The following is a description of a gene set: studied in species Homo sapiens A process in which a protein is transported to, or maintained in, a location within the Golgi apparatus. Human Gene Set: GOBP_PROTEIN_LOCALIZATION_TO_GOLGI_APPARATUS, and this is the list of marker genes: GBF1, LACRT, CSNK1D, RIPOR1, SYS1, RAB6C, RAB41, GOLPH3, GBP5, ARFRP1, VPS13A, ARL5C, PAQR3, GOLPH3L, VPS13D, IFT20, ARL5A, RAB6B, PACS1 (NCBI Gene Id 55690), VPS13C, RAB33B, SORL1, BICD2, TMED10, RAB6A, ARL1 (NCBI Gene Id 400), OBSL1, ATG9A, COG7 (NCBI Gene Id 91949), OPTN, RAB6D (NCBI Gene Id 150786), GAK, GCC2, ZDHHC15, ARL5B